The following is a description of a gene set: studied in species Mus musculus A multi-enzyme complex that catalyzes the oxidative decarboxylation of alpha-ketoglutarate (also known as 2-oxoglutarate) to form succinyl-CoA. The complex comprises multiple copies of three enzymes referred to as E1, E2 and E3: oxoglutarate dehydrogenase (lipoamide) (E1), dihydrolipoamide S-succinyltransferase (E2) and dihydrolipoamide dehydrogenase (E3). Additional proteins may also be present. Mouse Gene Set: GOCC_OXOGLUTARATE_DEHYDROGENASE_COMPLEX, and this is the list of marker genes: Bckdhb, Bckdk (NCBI Gene Id 12041), Ogdhl, Dlst, Ogdh, Bckdha, Mrps36, Dld, Kat2a, Abhd11